The following is a description of a gene set: Human Gene Set: GOMF_GLYCOLIPID_BINDING Binding to a glycolipid, any compound containing one or more monosaccharide residues bound by a glycosidic linkage to a hydrophobic group such as an acylglycerol, a sphingoid, a ceramide (N-acylsphingoid) or a prenyl phosphate. studied in species Homo sapiens, and this is the list of marker genes: CD1C, CLIP3, SELL, LAMB1, PPT1, SELP, PIGT, CLN6, FCGR3B, DPEP1, GPAA1, PIGU, GLTP, THY1, CLN3, CLEC4E, TPP1, PIGK, LAMA1, MAG, MANF, PSAP, TREM2, ULBP2, LYN, PLEKHA8, HSPA2, CEACAM5, RTN4R, IL2 (NCBI Gene Id 3558), EPDR1